The following is a description of a gene set: electronically inferred by orthology from the curated human pathway species: Mus musculus Reactome Pathway: Regulation of BACH1 activity This event has been computationally inferred from an event that has been demonstrated in another species.<p>The inference is based on the homology mapping from PANTHER. Briefly, reactions for which all involved PhysicalEntities (in input, output and catalyst) have a mapped orthologue/paralogue (for complexes at least 75% of components must have a mapping) are inferred to the other species. part of: KEAP1-NFE2L2 pathway, and this is the list of marker genes: Rps27a (NCBI Gene Id 78294), Mafk, Ubb, Cul1